The following is a description of a gene set: Human Gene Set: GOCC_PROTEASOME_REGULATORY_PARTICLE_BASE_SUBCOMPLEX studied in species Homo sapiens The subcomplex of the proteasome regulatory particle that directly associates with the proteasome core complex., and this is the list of marker genes: PSMC5, PSMC3, PSMD1, PSMC4, PSMC6, PSMD5, PSMC2, PSMD9, PSMD10, PSMC1, PSMD4, PSMD2